The following is a description of a gene set: studied in species Homo sapiens Any process that activates or increases the frequency, rate or extent of alpha-beta T cell activation. Human Gene Set: GOBP_POSITIVE_REGULATION_OF_ALPHA_BETA_T_CELL_ACTIVATION, and this is the list of marker genes: PNP, HSPH1, CD83, AP3D1, MALT1 (MALT1 paracaspase), IL12B, RHOA, IL12A, ADA, CD81, CBFB, SHH, SHB, PRKCQ, RUNX1, NLRP3, NCKAP1L, OPA1, CD3E, BRD2, SASH3, AP3B1, RIPK2, CD28, NKAP, ITPKB, TNFSF4, CD55, TGFBR2, CCR2, SOCS1, XCL1, HLA-A, HLA-DRB3, ZBTB16, ZAP70, MIR21, SOCS5, IL12RB1, ZBTB7B, PRKCZ, EP300, HLA-E, IFNG, IL23R, IL2RG, PTPRC, IL4R, CARD11, CD86, RUNX3, RASAL3, KLHL25, CD160, ANXA1, HLA-DRB1, NFKBIZ, IL23A, SYK, BRD4, GLI3 (GLI family zinc finger 3), LGALS9, HLA-DRA, CD80, NFKBID, LILRB4, RARA, IHH (NCBI Gene Id 50819), HLX (H2.0 like homeobox), EBI3, CCL19, GPR65, FOXP3, IL18, JAK2, TYK2